Given this list of marker genes AUP1, NEGR1, SQLE, BSCL2, PLA2G4C, MOSPD2, LDAF1, CDS2, PISD, FITM1 (NCBI Gene Id 161247), SMIM22, CDS1, RNF213, FITM2, ZFYVE1, here is a description of the gene set: A process that results in the assembly, arrangement of constituent parts of a lipid droplet. Human Gene Set: GOBP_LIPID_DROPLET_FORMATION species: Homo sapiens